The following is a description of a gene set: Human Gene Set: HP_LARGE_SELLA_TURCICA studied in species Homo sapiens An abnormal enlargement of the sella turcica. Large sella turcica, and this is the list of marker genes: ZSWIM6, SOST, GLB1, CDH23, ATRX, TBC1D2B, NR3C1, TP53, GNPTAB, USP8, BRAF, TSHB, USP48, PCNT, ABCC9